Given this list of marker genes Phf5a, Prpf4, Ddx39b, Sf3a3, Snrpa, Sox2, Pou5f1, here is a description of the gene set: miRNAs and TFs in iPS Cell Generation species: Mus musculus Mouse Gene Set: WP_MIRNAS_AND_TFS_IN_IPS_CELL_GENERATION